The following is a description of a gene set: Human Gene Set: MORF_PML studied in species Homo sapiens Neighborhood of PML promyelocytic leukemia in the MORF expression compendium Neighborhood of PML, and this is the list of marker genes: ZKSCAN3, CSNK1D (NCBI Gene Id 1453), PRSS16, TUB, WWOX, CARD10, NUDT3, RABAC1, SLC30A3 (NCBI Gene Id 7781), KIFC3, GPR35, PFDN1, PNMT, ARSL, MCRS1, HMG20B, GPR161, LSM12, FANCG, PTPN9, TRA2A, CDK5R1, KAT8, RBBP8, DRG2, BCL2, PAX8 (NCBI Gene Id 7849), ITPR2, TMEM94, PLIN3, IRF2BP1, MGAT1, PRKCSH, PIGB, HSF4, SLC5A2, CRHR2, TNP1, GGT5, RABGGTA, ADAMTSL2, MTX1, EPOR, CRYBA4, PRPH, KLHL18, PCGF2, RPS6KB2, PLK3, MSX1, TSPO2, ANKRD12, MR1 (major histocompatibility complex, class I-related), WDR62, EXTL3, SLC22A24, BTD, MCM3AP, DDX11, ZBED1 (NCBI Gene Id 9189), CALCOCO1, FDXR, ARAF, CRCP, PCBP3, IKBKG, HMGXB3, GRIK5 (NCBI Gene Id 2901), PCGF1, IFT140, CAMK2B (calcium/calmodulin dependent protein kinase II beta), MYO9B, TNFRSF25, SLC30A1 (NCBI Gene Id 7779), IGSF9B, SLC6A7, ITGAV, NEURL1, SLC12A4, GHITM, ADAM15, JAK3, DGCR11, PVT1, B4GALT3, F7, FKBP15, PPP1R10, MT4 (metallothionein 4), SDC3, KHNYN, CASP2, IGHMBP2, ARPC4, MOK, AMFR, MC2R, TPMT, NDST1 (N-deacetylase and N-sulfotransferase 1), IRF2, ENTREP1, PML, ZNF592, HSPB2, ACKR2, CNTN2, SPTB, ATOSB, MYL2, MPP2, RBM8A, LBP, SLC6A9, BAHD1, HTR7, AQP5, LINC00928, NTSR2, TUBGCP2, EML3, AP2A2, ACR, NFRKB, SSTR5, SPEF1, DHRS1, SH2B1, DOK1, IKBKE, USP19, CD40, HTR4, SLC2A1, PMF1, ENTREP3, MMP25, ARC, CNP, LPAR2, SLC24A1, SLC9A1, SIK3, HAUS5, CNOT4, LTK